Given this list of marker genes IGF2BP1, MAP3K1, SNX16, ZNF850, GALC, GAN, NAP1L1, GPRASP1, HOXB7, PSMD11, RASSF3, GATA6, NTN4, TRERF1, HOXA5, HOXA7, ST6GALNAC5, HIP1 (NCBI Gene Id 3092), ARHGAP28, FNIP1, DENND6A, MCM9, HOXC8, ZNF281, SNX24 (NCBI Gene Id 28966), PHF20, VAX1, RNF10, RBM8A, P2RY1, PHF8, CREBL2, OPA3, EPHA7, PBX1, KCNJ2, TRMT1L, NR2C2, ERI2 (ERI1 exoribonuclease family member 2), TMEM121B, PLD1, SMC3, PRTG, GTF2A1 (NCBI Gene Id 50857), MAP4K3, RCC2, HMGA2, DYNC2LI1, TYW5 (tRNA-yW synthesizing protein 5), HAND1, NXPE3, SEMA3A, TSTD3, LRIG3, PACRGL, DIP2A, TAFA5, FRMD4B, CCNJ, ZMYND11, SLC9A6, BRAP, PRKG1, SFMBT1, LCOR, ELAVL4, CASK, ACER2, NR6A1, PTPRG, NKAPD1 (NKAP domain containing 1), HOXB6, SRRT, VSNL1, EXOC8, CBFA2T3, DCDC2, NRAS, POLR3D, CEP350, HOXA9, PPP1R15B, LRIG2, LRP1B, GPATCH2L, TRMT10A, RDX, IGF2BP3, MAPK8, RASGRP1, MECP2, CCDC47, ABL1, AQP4, here is a description of the gene set: species: Homo sapiens Human Gene Set: MIR196A_5P_MIR196B_5P Genes predicted to be targets of miRBase v22 microRNA hsa-miR-196a-5p, hsa-miR-196b-5p in miRDB v6.0 with MirTarget v4 prediction scores > 80 (high confidence targets). from publication Chen Y, Wang X (PMID 31504780)